Given this list of marker genes ALK, here is a description of the gene set: ASP3026 is a second generation tyrosine kinase inhibitor with activity against ALK fusions in non-small cell lung cancers (NSCLC) and anaplastic large cell lymphomas (ALCLs). This pathway describes ALK mutants that are resistant to inhibition by ASP3026 part of: Drug resistance of ALK mutants Reactome Pathway: ASP-3026-resistant ALK mutants studied in species Homo sapiens